The following is a description of a gene set: part of: Viral Infection Pathways Reactome Pathway: Respiratory Syncytial Virus Infection Pathway studied in species Homo sapiens Infection with human respiratory syncytial virus (hRSV) is transmitted through close contact, fomites, and aerosolized droplets. RSV first infects the epithelial lining of the upper respiratory tract and nasopharynx where the virus begins to replicate, and from there it may spread to the lower respiratory tract - bronchioles and alveoli - especially in infants. Immune response to RSV infection increases mucus production which, in combination with inflammation, leads to the narrowing of airways and bronchiolitis. Experimental vaccination with a formalin-inactivated RSV has been associated with vaccine-enhanced disease, which has hindered vaccine development and led to advancement of costly and modestly effective therapies based on monoclonal antibodies (mAb) and small molecules, which act to block RSV entry and have been reserved for high-risk patients. Recently, a prophylactic mAb Nirsevimab was approved for use in all infants. Some of the preF vaccines, which elicit immune response against the pre-fusion conformation of the F protein (pre-F), are in the late stages of clinical trial or undergoing approval for being used in elderly patients and pregnant women.<br><br>RSV is classified into two distinct subtypes, RSV A and RSV B, predominantly based on antigenic and sequence-based variations in the viral envelope protein G, involved in virus attachment to the host cells. Multiple RSV genotypes are often in co-circulation with a dominance shift between RSV A and RSV B subtypes occurring every 1-2 years. The majority of RSV molecular studies use a limited number of historical isolates, the so-called laboratory strains, of which hRSV A substrain A2 is the most commonly used. If not indicated otherwise, the events described in this pathway refer to findings from hRSV A2-based studies.<br><br>For review, please refer to Battles and McLellan 2019, and Pandya et al. 2019., and this is the list of marker genes: IFNB1, MED4, GPC3, SDC1, TLR7, 1C, MAP1B, IFNA6, EGFR, CX3CR1, GPC4, GPC2 (NCBI Gene Id 2818), IGF1R, RAB5C, M2-2, RPS27A, MAVS, CREBBP, EIF2AK2, MED12, MED13L, HERC5, UBB, GPC5, LY96, IFNA8, JAK1, CD14, IFNA14, TLR2, MED19, CSNK2A2, CDK19, MED21, IFNA4, MED15, CUL5, IFNA2, SDC4, L, MED31, CDK8, GPC6, SPCS3, MED6, RIGI, KPNB1, RAB5A, MED18, SDC2, ELOC, MED14, GPC1, HSP90AA1, RAB5B, MED7, UBA52, M2-1, H2BC15, MED10, UBE2L6, SPCS2, IFNA5, TLR6, HSPA8, M, IFNA1, CLEC4M, P, MED9, PPP1CC, SEC11A, EP300, TRIM25, MED17, STAT2, MED28, IFNAR1, IFNA21, BCAP31, MED25, TLR3 (toll like receptor 3), MED23 (mediator complex subunit 23), CD209, IFIH1, MED22, HSP90AB1, SPCS1, PPP1CB, ARIH1, G, ISG15 (ISG15 ubiquitin like modifier), MED26, IRF3, ELOB, TYK2 (NCBI Gene Id 7297), IFNA7, MED24, SDC3, MED8, MED20, 1B, MED1, CSNK2B, IFNA10, MED11, MED27, OAS2, RBX1, IFNAR2, NCL, XPO1, N, AGRN, SEC11C, TLR4, MED16, F, Human respiratory syncytial virus A2, complete genome, HSPG2, UBC, BECN1, MED13, IFNA17, FURIN, SH, MED30, MED29, Human respiratory syncytial virus A, IFNA16, CCNC, CSNK2A1, PPP1CA